The following is a description of a gene set: A cell junction that mechanically attaches a cell (and its cytoskeleton) to neighboring cells or to the extracellular matrix. species: Homo sapiens Human Gene Set: GOCC_ANCHORING_JUNCTION, and this is the list of marker genes: KRIT1, KIAA1210, PARD6G, TBC1D2, SLC8A1, SH3BP1, RPL7, GJA10, C1QTNF5, RASIP1, VSIG10, LIMA1, BLOC1S6, LIN7A, ARHGEF7, XIRP1, SSX2IP, PRKCI, FZD4, MAP4K4, RPLP2, ALCAM (activated leukocyte cell adhesion molecule), MPZL1, PFN1, FES, PPP1CC, SIRT2, PLAU, CLDN16, BSG, ITGA11, NFASC, SPTBN2 (spectrin beta, non-erythrocytic 2), P2RX7, GAK, PTPRU, WNK3, CORO1C, WASF2, DSP, ATP6V0C, JAG1, NHS, CTNNB1, MAGI3, FAP, SENP1, DSC2, LRP1, ITGA8, CDH26, CFL1, FLCN, SPTBN4, SORBS3, EPPK1, TRPC4, RRAS, CDH4, ADAM10, CADM3 (cell adhesion molecule 3), PCDHGA12 (NCBI Gene Id 8640), CSK, ADA, STARD10, PKN2, LAMTOR3, COL17A1, ADAM15, ATN1, MMP14, LAYN, CXADR, HSPA9 (NCBI Gene Id 91471), PRKCZ, EGFR, GJB3, WASF1, AMOT, DLC1, TMEM204, MAP2K2, GJB5, TJP1, GJB2, CLDN5, RAP2B, KLF11, PDLIM5, PKP1, TNFSF13B, CLDN8, PRIMA1, PARVA, WTIP, GAB1, SLC4A2, AJM1 (apical junction component 1 homolog), TLE2, KDR, ALOX15B, MICALL2, VASP, NCK1, GFRAL, YES1, SRC, ARL14EP, PPL, APOLD1, CD46, VANGL2, CSPG4, STX16, RAB13, RPL5, TRIM15, GJD4, PMP22, CLDN3, NECTIN1, CDH18, BBLN, SRCIN1 (NCBI Gene Id 80725), DAB2, S100A11, TGFB1I1, COL13A1, GJA3, CLDN14, NIBAN2, PRUNE1, CDSN, CXCR4, PTPRJ, FLOT2, MPP4, FLNC, GJC1, AHI1, PDZD11, CAPN5, FRS2, BCAR3, RPS29, AOC1, CAV3, PARVG, CDK4, CDHR3, CAT, ESAM, IL16, SVIL, ASH1L, VEZT, CTNND2, SCRIB, ARHGEF5, PTK7, SLC9A5, FERMT3, SCN1A, NECTIN3, CYFIP1 (cytoplasmic FMR1 interacting protein 1), GSN, CD44, PGM5, ACTR2, PTK2, ACTC1, CRB3, RPS5, PRKCG, WWTR1, CDC42EP1, TIAM1, PTPN6, PPFIA1, RHOB, HSPA1B, PAK4, NHERF4, DSG4, CLDN7, MARVELD3, PTPRK, FAT2, EPHA4, CNN1, VAMP5 (vesicle associated membrane protein 5), ADAM17, RND3, CTTN, ITGA4, GDI2, GJA4, MARCKS, PALS1, LPP, SAPCD2, CLDN1, RPS2, DDX6, RPL4, SLC2A1 (solute carrier family 2 member 1), PIP5K1A, HYOU1, AMTN, MAPK15, NRP1, PLEKHA7, B2M, DLG4, NPHP1 (NCBI Gene Id 4867), ABCC2, KRT80, AKAP12, RHOU, CLDN34, ANKRD23, TES, CLCA2, ILK, ITGAV, DMD, CCND1, CDH5 (cadherin 5), MAPRE2, CNKSR1, SDCCAG8, CLASP1, PEAK1 (NCBI Gene Id 79834), LYN, MPDZ, CLDN6, DNMBP, MTDH, DSG3, JAM2, LMO7, RPLP0, CLDN24, RAI14, ARHGAP24, PRKAR2A, LAMA1, DIXDC1, RPS14 (ribosomal protein S14), CCDC85B (NCBI Gene Id 11007), YAP1, BMPR2, MYZAP, PALLD, RPL8, SDC4, SYNM, RPS19, AMOTL2, NCSTN, EVL, CTNNA3, PTPRA, PDXP, HMCN1, ILDR1, S100A7, RPL3, ACTN2, CLTC, ITGB1BP1, AVIL, SHROOM4, LCP1, PDPK1, PARVB (NCBI Gene Id 29780, parvin beta), TADA1, DES, ZNF185, PIK3CA, CADM1, ITGB5, TGM2, FRMPD2, PARD6A, ACTN3, LLGL1, LIMK1, PACSIN2, PABPC1, ABCB11, DCTN4, SORBS2, ATP2A2, RPS9, AJUBA, RPS18, SNTB1, ARVCF, RAPGEF2, CDH3, CLDN22, CORO2B, APBB1IP, PPP1R12A, CD9, FOCAD, RPS16, TMEM47, SH3PXD2A, RPS3, RUFY3, CAPN2, SLC8A3, CCDC88C, SH3GL1, MPRIP, AKT1, ADCYAP1R1, SCARB2, NRAP, THEMIS, AFDN, HSPG2, CLDN20, FRMD5, DOCK5, TNS3, STEAP1, SIGMAR1, PRICKLE4, LDB3, JAM3, PAK2, RPS7, HSP90B1, PANX3, DSC1, LAMA3, YWHAE, PKP4, PPP1CB, OPALIN, PRAG1, YWHAH, FXYD1, AIF1L, DOCK7, ADAM9, EIF4G2, CYTH2, ARHGAP31, RPL19, CDH17, ECT2, PHLDB2, TLN1, RALA, RTN4, CDC42BPA, CDC42BPB, CD53, KIRREL3, ITGA5, UBN1, SLC3A2, FHL1, PLEKHG5, BAIAP2, YWHAG, CCN3, ITGA6, B4GALT1, FBLIM1, ABI2, TNS4 (tensin 4), RPL9, RDX, CAMSAP3, ITGA2B, CDH11, ITGB7, FZD2, ZAP70, CDH20, SCN1B, SNAP23, ARF6, MARVELD2, YWHAB, ILDR2, POLDIP2 (NCBI Gene Id 26073), RPS4X, ALKBH6, TENM2, FAT1, SGCA, CTNND1, STXBP6, KRT8, FLNB, KIT, KRT18, ACTR3, GRB2, UBOX5, CDC42, MDC1, GNA13, NPHS2, AMBRA1, JAK2, RRAS2, CD3E, FLRT2, ANXA1, HCK (NCBI Gene Id 3055), WNK4, NECTIN2, CLDN17, AQP3, DPP4, ITGB8, MAGI2, NEXN, HACD3, SHROOM3, SLC31A1, SPATA13, ERC1, EPB41L4B, SGSM3, EFS, VCL (NCBI Gene Id 7414), PAK1, PROCR, GJB6, GJC2, PI4KA, DSG2 (NCBI Gene Id 1829), WAS, NEDD9, SHROOM1, TNS2 (tensin 2), ANO7, ITGB6, DBNL (drebrin like), FLRT1, LAT, RPL27, ABCB4, SCIN, GJB7, KIF23, NHERF2, CCDC85A, ITGB2, NME2, KIFC3, SLC9A1, PERP, TSPAN4, CLDN18 (claudin 18), F11R, YWHAZ, SV2A, DST, VAPA, TNS1, MAGI1, RHOA, EPHA2, RND1, ACTB, HNRNPK, CCDC85C, RPL12, PTPN12, RPL30, PCDH1, MRC2, DLL1, CORO1B, SYNE2, PPIB, TJAP1, ACTG1, XIRP2, CLDN11, RPL6, FRMD6, GJD2, ATP1A2, SSH2, PLEC, PARD6B, PRKCD, ITGB3, LIMS1, CLDN4, CLDN9, CBL, NOX4, RPS15, RPL22, FERMT1, CAV2, SMPX, IGSF5, MYH9, PANX1, FHL3, RAB10, ZYX, FCHSD2, PDLIM4, PCDHA10 (NCBI Gene Id 56139), AKAP6, LASP1, FLOT1, TNK2, FRMD4A, PPFIBP1, TJP3, PODXL, MICALL1, SCN8A, PNN, TRIM29, LLGL2, FSCN1, SPRY4, FBF1, ARHGEF2, FRMD4B, CD151, CASK, CLDN15, NPM1, CORO1A, NCKAP1, MISP, FMN1, RPL38, AMOTL1, CALB2, KLHL24, PARD3B, DLG2, NPHP4, ARHGEF6, PIP5K1C, MPP1, FLT1, SCN5A, RPS17, FHOD1, EFNA5, EFNB2 (NCBI Gene Id 1948), CDH22, ADGRE5, PEAK3, LCK, CEACAM1, TWF1, ASAP3, CTNNA2, PIK3R1, BVES, HSPA1A, GRB7, GJA1, MPP2, IGF2R (insulin like growth factor 2 receptor), FHL2, EHD3, ATP1B1 (NCBI Gene Id 481), GIT2, EPB41L3, CLIC4, REXO2, MPP7, CAV1, AJAP1, CLDN10, SKAP1 (NCBI Gene Id 8631), AFAP1L1, MYH1, PDCD6IP, ADD3, LSR, MCAM, PLPP3, SLC2A2, THSD1, SNTA1, JUP, AQP7, MLC1, IGSF11, CLASP2, EHD4, PDLIM2, KIRREL1 (kirre like nephrin family adhesion molecule 1), LIMS2, DLG5, ERBIN, CTNNA1 (NCBI Gene Id 619480), GJA5, CDH7, ARPC5L, PTK2B, HSPA8, NPHS1 (NPHS1 adhesion molecule, nephrin), PRX, APC, USP53, RSU1, HAVCR2, DUOX2, PDGFRB, ADD1, FYB1, KDF1, EPB41L2, MAPK1, ENAH, AFAP1, CD99L2, ITGBL1 (NCBI Gene Id 9358), RAC1, VEGFA, OCLN, NOX1, STRN, CDH6, RPL18, TBCD, STARD8, P4HB, SHC1, YWHAQ, HEG1, ADGRB1, PPIA, CLDN2, VSIG10L2, FZD1, FLRT3, ANK2, PARK7, CDHR2, FZD5 (NCBI Gene Id 81561), CDC42EP4 (CDC42 effector protein 4), TRIOBP, JCAD, RPS11, NOTCH1, IRF2, DSC3, LIN7C, GJA9, FAM107A, TJP2, VIM, KRAS, ARHGAP21, PXN, CLDN12, RPGRIP1L, TNKS1BP1, SNTB2, FER, TPM4 (tropomyosin 4), PPP1R9B, KIRREL2, SRP68, CHP1, ENG, MAP3K1, GJD3, ARMC5, CLDN23, DAG1, RAB21, IQGAP3, KAZN, TEK, FGFR4, L1CAM, NECTIN4, CDH9, ATP6V0A2, MAPK3, MIP, LUZP1, KCNJ2, DDR2, NGFR, PTPRM, TLN2, RPL13A, BIN2, WDR1, MYO1E, CNN3, ITK, GJA8, ARPC1B, DND1, ARPC5, KCNA5, OBSL1, KCNA1, CDH12, HPN, NUMB, HEPACAM (hepatic and glial cell adhesion molecule), ADGRL3, BAIAP2L2, GRIA1, CIB2, RAP2C, EPCAM, GNB2, RAP1B, ANXA2, RPS10, KCNA2, SHROOM2, DLG3, PRKD1 (NCBI Gene Id 5587), RPLP1, ANXA6, LPXN, LCP2, PIK3R2, MME, CDCA3, PCDH9, CAPN1, CDH8, ARHGAP22, USP33, RPL10A (NCBI Gene Id 4736), MAPRE1, PLAUR, SDCBP, FERMT2, CNN2, PECAM1, STX3, G3BP1, CD2 (CD2 molecule), CD99, TSPAN33, RHO, KCND2, UBA1, TRPV4, CLDN25, SH3PXD2B, ITGB1 (integrin subunit beta 1), SMAD7, TRIP6, YBX3, PVR, ACTN1, CAP1, SYNPO, CGN, NDRG1, GJC3, PDLIM7, POF1B, DBN1, MPP3, DSG1, HMGA1, RPS13, CNTNAP2 (contactin associated protein 2), PARD3, RPL7A, BAIAP2L1, RHOG, EZR, CLMP, GJB1, CALR, TCHP, NOS1AP, DLG1, FGFRL1, LIN7B, MSN, ARPC2, ZFYVE21, RPS8, HSPA5, PDLIM3, PDIA3, CDH24, PKP3, LIMD1, LAP3, PDZD2, CD81, ITGA2, ITGA3, ACTN4, EVPL, MAP2K1, ICAM1, PPP1CA, ATAT1, OCEL1, CDH19, VAV1, CLDN19, PTPRC, BCAR1, RPL31, FGFR3, TSPAN9, CDH15, CD59, GJB4, LRRC7, ARPC3, FBLN7, TRPC6, RIGI, TM4SF20, FLNA, ARF1, RPL23, RANGRF, SH3KBP1, PKD2, ITGB4, CNTNAP1, PDLIM1, IL1RL1, DNM2, ANK3, MXRA8, CYBA, IQGAP1, GRHL2, SCN4B, MYH2, CADM4, SIPA1L3, CRB2, ANXA5, ARHGAP26, CYTH3, SCARF2, SYMPK, PATJ, LMLN, DSTYK, FGF13, JAK1, TNC, RPL37A, PLEKHG4B, TMEM65, PRKCH, ITGA1, GNA12, MYADM, PCBP2, PDPN (podoplanin), SPECC1L, PKP2, ARHGAP17, HSPB1, CPNE3 (copine 3), FLII, RPS3A, THY1 (NCBI Gene Id 94105), FBP2, TGFBR1, PLXDC1, PALS2, TRAF4, GIT1, SLC6A4, PCDH12, JAML, EPB41L5, CASS4, SYNPO2, RAC2, CDH1, CYTH1, CDH10, WWP1, SORBS1, IGSF21, CGNL1, CDH13, AHNAK, CRB1, TMOD3, CD2AP, CSRP2, NF2, GJE1, CSRP1, RAP1A, CDH2